The following is a description of a gene set: The process in which the anatomical structures of the paraxial mesoderm are generated and organized. studied in species Homo sapiens Human Gene Set: GOBP_PARAXIAL_MESODERM_MORPHOGENESIS, and this is the list of marker genes: BMPR1A, LEF1, NCKAP1, SMAD2, WNT5A, WNT11, FOXC2, FOXC1, SMAD3, EXOC4, WNT3A